The following is a description of a gene set: Human Gene Set: MIR548V Genes predicted to be targets of miRBase v22 microRNA hsa-miR-548v in miRDB v6.0 with MirTarget v4 prediction scores > 80 (high confidence targets). from publication Chen Y, Wang X (PMID 31504780) studied in species Homo sapiens, and this is the list of marker genes: PTBP2, MARK1, RGS6, ZNF234, ZNF704, DPH6, UBE2J1, SEMA6D, SUN2, ECPAS, FGA, MAPK8, ZNF814, RBM14-RBM4, PGGT1B, VAPB, SEPTIN2, ARHGEF10 (NCBI Gene Id 9639), KLF7, ANO1, RMND5A, PIAS2 (NCBI Gene Id 9063), CEP350, SLC6A9, SH3PXD2B, ZNF431, MAP3K13, PBX3, PPIAL4D, SATB1, PRKCQ (protein kinase C theta), CAND1, GATA4, AP3B2, SEC62, KCNH8, SDC2, EFCAB14, CDKN1B, TDRKH, HNRNPA0, ZNF385A, FGF14, VPS52, CTTN, CNOT6, CLVS2 (clavesin 2), CALM1, ELAVL2, REV1 (NCBI Gene Id 51455), RTF1, PSMA4, ZBTB5, GABRA1 (gamma-aminobutyric acid type A receptor subunit alpha1), EAF1, CDK19, NOVA1, PPIAL4G, PIEZO2, PPIAL4E, CTNNA2, TMEM59, NEXMIF, GUCY1A2, CHFR, PPIAL4C, ZNF587B, SOS2, CSTF2T, RIMS3, RTL4, ETS1, SLC3A1, DTX3L, CUL5, TCF7L2, DDIT4, SLC44A5, LNX2, GOLGA1, TP53BP2, TNRC6C, ZNF3, SELENOS, ZFYVE16, RBSN, NUFIP2, ACTL7A, ZMYM2, RIC8B, PPP2R2A, POU2F1, FBN2, CDC40, MIER3, RTN1, TSPAN5, CREM, COBL, TCF12, USP49, DENND1B, IGDCC4, STOX2, YPEL3, APOLD1, RNPS1, ATP1B1, HECTD2, AJAP1, RAB18, FAM222B, ZNF629, USP40, FAHD1, SLITRK4, CTPS2, SLC10A7, GRM1, ATF7IP2, AIDA, TMEM140, RBM4, CDH2, PAIP1 (NCBI Gene Id 10605), TIPRL, LHFPL2, PPIAL4F, THEMIS2, EIF5A2, RIMS1, CDK8, MYLIP, DMRT3, MYOG, ERV3-1, PPIAL4A